The following is a description of a gene set: studied in species Mus musculus Binding to a laminin, a major glycoprotein constituent of the basement membrane of cells. Mouse Gene Set: GOMF_LAMININ_BINDING, and this is the list of marker genes: Lrrc15, Shh, Dag1, Itga9, Ssc5d, Itga7, Ntn4, 2300002M23Rik, Pxdn, Adgrg6, Adam9, Lgals1, Thbs4, Nid1, Lypd3, Gpc1, Itga2, Itga6 (integrin alpha 6), Slit2, Ctss, Ncl, Agrn (agrin), Ache, Rpsa, Itga3, Fkrp, Plekha2, Bcam (basal cell adhesion molecule), Lgals3 (NCBI Gene Id 16854), Itgb1, Tinagl1, Thbs1